The following is a description of a gene set: species: Mus musculus Mouse Gene Set: MIR_149_5P Genes predicted to be targets of miRBase v22 microRNA mmu_miR_149_5p in miRDB v6.0 with MirTarget v4 prediction scores > 80 (high confidence targets). from publication Chen Y, Wang X (PMID 31504780), and this is the list of marker genes: Phlpp2, Tmem135 (NCBI Gene Id 72759), Trps1, Hfe, Ddi2, Hcrtr2, Phlda3, Pou2f2, Atg4a, Foxc1, Csn1s2a, Phldb1, Pmm2, Zfp787, Tnfrsf19, Clvs2, Reps2, Kcnb1, Zfp710, Tor3a, Sh3pxd2a, Etaa1, Cnih4, Brd10, Aff3, Gm3636, Sema4g, Ccdc97, Luc7l, Sh3gl1, Iffo2, Map4k5, Slc8a1, Zfp335, Ccdc125, Syt2, Fbxo41, Zfp958, Fasl, Mprip, Rsbn1l, Lrrc32, Ror1 (NCBI Gene Id 72176), Pde1a, Gm10413, Plcxd1, Edar, Rnf2, Asb4, Eloa, Faap20, Tcerg1 (transcription elongation regulator 1 (CA150)), Zbtb4, Lsm14b, Grin2d, Cbx3, Snrk, Or10al5, Ncald, Rap1a, Nfix, Sncaip, Marcksl1, Ccni, Tnks, Gm3317, Ube2z, Pcdh19, Cmtm7, Frrs1l, Zbtb2, St8sia6, Ext1, Gpr17, Ndst1, Lmbr1l, Ska3, Aak1, Igf2bp1, Rab6b, Ufm1, Cdh26, Hic2, Tmbim1, Fli1, Amotl2, Adcy1, Appl2, Golt1b, Fkbp1b, Arhgap21, Them6, Il17rd, Pkp2 (plakophilin 2), Klhl23, Lenep (lens epithelial protein), Zmat4, Fbxl16, Cct3, Prkab1, Dll1, Pde4b, Brix1, Gm10406, Ube2w, Arel1, Kmt2d, Plcxd2, Scfd1, Iqsec2, Nr4a3, Tirap, Rft1, Nrp2, Casp2, Gm3488, Plpp3, Polr2c, Dnm3, Prr36, Rab3il1, Cand2, Gm5795